Given this list of marker genes IFI30, SOCS3, PARP9, OAS1, RSAD2, DTX3L, NFIX, IFI44, PRPF31, GBP4, GBP5, GBP2, UBE2L6, ICAM1, CIMAP1B, ETV7, MUC1, TRAFD1, CETP, CD38, IRF8, CEACAM1, IFIT3, ACOT7, TYMP, IFI44L, SMTNL1, RGS1, SAMD4A, SAMD9L, FBXO6, STAT1, BCL3, EPSTI1, APOL6 (NCBI Gene Id 80830), TNFSF13B (NCBI Gene Id 89794), XAF1, IRF1, CMPK2, GBP1, CSF1, IFI35, here is a description of the gene set: Genes up-regulated in T cell 1d vs 0d in adults (18-49) after exposure to inactivated monovalent influenza A/Indonesia/05/2005 H5N1 split-virus vaccine, time point 1D, administered i.m. species: Homo sapiens BACKGROUND: Vaccine development for influenza A/H5N1 is an important public health priority, but H5N1 vaccines are less immunogenic than seasonal influenza vaccines. Adjuvant System 03 (AS03) markedly enhances immune responses to H5N1 vaccine antigens, but the underlying molecular mechanisms are incompletely understood. OBJECTIVE: We compared the safety (primary endpoint), immunogenicity (secondary), gene expression (tertiary) and cytokine responses (exploratory) between AS03-adjuvanted and unadjuvanted inactivated split-virus H5N1 influenza vaccines. In a double-blinded clinical trial, we randomized twenty adults aged 18-49 to receive two doses of either AS03-adjuvanted (n = 10) or unadjuvanted (n = 10) H5N1 vaccine 28 days apart. We used a systems biology approach to characterize and correlate changes in serum cytokines, antibody titers, and gene expression levels in six immune cell types at 1, 3, 7, and 28 days after the first vaccination. RESULTS: Both vaccines were well-tolerated. Nine of 10 subjects in the adjuvanted group and 0/10 in the unadjuvanted group exhibited seroprotection (hemagglutination inhibition antibody titer > 1:40) at day 56. Within 24 hours of AS03-adjuvanted vaccination, increased serum levels of IL-6 and IP-10 were noted. Interferon signaling and antigen processing and presentation-related gene responses were induced in dendritic cells, monocytes, and neutrophils. Upregulation of MHC class II antigen presentation-related genes was seen in neutrophils. Three days after AS03-adjuvanted vaccine, upregulation of genes involved in cell cycle and division was detected in NK cells and correlated with serum levels of IP-10. Early upregulation of interferon signaling-related genes was also found to predict seroprotection 56 days after first vaccination. CONCLUSIONS: Using this cell-based systems approach, novel mechanisms of action for AS03-adjuvanted pandemic influenza vaccination were observed. TRIAL: ClinicalTrials.gov NCT01573312. from publication Howard LM, Hoek KL, Goll JB, Samir P, Galassie A, Allos TM, Niu X, Gordy LE, Creech CB, Prasad N, Jensen TL, Hill H, Levy SE, Joyce S, Link AJ, Edwards KM (PMID 28099485) Human Gene Set: HOWARD_T_CELL_INACT_MONOV_INFLUENZA_A_INDONESIA_05_2005_H5N1_AGE_18_49YO_1DY_UP